Given this list of marker genes NOTCH3, NDUFA4L2, REN, EGFEM1P, DAAM2-AS1, COLEC10, OLFM2, LINC00993, FAM182B, ABCC8, PELO, ARHGAP44, HIGD1B, C9orf153, FOXF2, LZTS1, WNT3A, COL13A1 (collagen type XIII alpha 1 chain), PAG1, NGFR, FAM228A, RGS20, CACNA1C (calcium voltage-gated channel subunit alpha1 C), GRID1, HAS2, ERFE, VASH2, KCNS3, GFRA2, PLA2G2A, ADARB2, PDLIM3, ABCC9, SCN11A, CCDC102B, POSTN, CIB4, COL5A3, CCDC68, ADAMTS20, ITGA9, KCNK3, FAM162B, PGM5, LAMC3, CLTCL1, TRPC3, ADGRB1 (NCBI Gene Id 575), SEMA5B, TBX5, BMPER, LIPG, CSPG4, SCN4B, PLA2G5, LINC01099, ANGPTL6, PAQR5, AFF2, CHRM2, AGTR1, ADAMTS18, GPR20, MAPT, HECW2-AS1, CACNA1C-IT3, GUCY1A2, GJC1, EGFLAM, SCN7A, CARMN, BMPR1B, KCNK17, COX4I2, ADAMTSL3, GNAL, SEPTIN4, LINC02082, ADRB3, LINC02889, PLCB1, ANKRD30A, PLCB1-IT1, CCDC3, CNTN4, RASL12, HEYL, CDH19, here is a description of the gene set: Marker genes curated from the annotated cluster as represented in the Descartes Human Gene Expression During Development database. studied in species Homo sapiens Human Gene Set: DESCARTES_FETAL_PLACENTA_SMOOTH_MUSCLE_CELLS The gene expression program underlying the specification of human cell types is of fundamental interest. The study authors generated human cell atlases of gene expression and chromatin accessibility in fetal tissues. For gene expression, the study authors applied three-level combinatorial indexing to >110 samples representing 15 organs, ultimately profiling ~4 million single cells. The study authors leveraged the literature and other atlases to identify and annotate hundreds of cell types and subtypes, both within and across tissues. Our analyses focused on organ-specific specializations of broadly distributed cell types (such as blood, endothelial, and epithelial), sites of fetal erythropoiesis (which notably included the adrenal gland), and integration with mouse developmental atlases (such as conserved specification of blood cells). These data represent a rich resource for the exploration of in vivo human gene expression in diverse tissues and cell types. from publication Cao J, O'Day DR, Pliner HA, Kingsley PD, Deng M, Daza RM, Zager MA, Aldinger KA, Blecher-Gonen R, Zhang F, Spielmann M, Palis J, Doherty D, Steemers FJ, Glass IA, Trapnell C, Shendure J (PMID 33184181)